Given this list of marker genes NOG, CELSR1, FGF10, AR, VANGL2, TP63, SULF1, WNT5A, FGFR2, BMP4, BMP7, SHH, here is a description of the gene set: The process in which a branch forms along the side of an epithelium. species: Homo sapiens Human Gene Set: GOBP_LATERAL_SPROUTING_FROM_AN_EPITHELIUM